The following is a description of a gene set: Human Gene Set: BAE_BRCA1_TARGETS_DN Genes concordantly down-regulated in DU-145 and MCF-7 cells (lprostate, breast cancer) upon expression of BRCA1. from publication Bae I, Fan S, Meng Q, Rih JK, Kim HJ, Kang HJ, Xu J, Goldberg ID, Jaiswal AK, Rosen EM (PMID 15520196) species: Homo sapiens Mutations of the breast cancer susceptibility gene 1 (BRCA1), a tumor suppressor, confer an increased risk for breast, ovarian, and prostate cancers. To investigate the function of the BRCA1 gene, we performed DNA microarray and confirmatory reverse transcription-PCR analyses to identify BRCA1-regulated gene expression changes. We found that BRCA1 up-regulates the expression of multiple genes involved in the cytoprotective antioxidant response, including glutathione S-transferases, oxidoreductases, and other antioxidant genes. Consistent with these findings, BRCA1 overexpression conferred resistance while BRCA1 deficiency conferred sensitivity to several different oxidizing agents (hydrogen peroxide and paraquat). In addition, in the setting of oxidative stress (due to hydrogen peroxide), BRCA1 shifted the cellular redox balance to a higher ratio of reduced to oxidized glutathione. Finally, BRCA1 stimulated antioxidant response element-driven transcriptional activity and enhanced the activity of the antioxidant response transcription factor nuclear factor erythroid-derived 2 like 2. The ability of BRCA1 to stimulate antioxidant response element-dependent transcription and to protect cells against oxidative stress was attenuated by inhibition of nuclear factor erythroid-derived 2 like 2. These findings suggest a novel function for BRCA1, i.e., to protect cells against oxidative stress. This function would be consistent with the postulated role of BRCA1 as a caretaker gene in preserving genomic integrity., and this is the list of marker genes: CAD, TNFAIP6, ZNF135, HIPK3, EBI3, CRAT, THBS1, TCOF1, STIL, TJP1, NPM1, TJP2, BAG1, GLUD1, TNFAIP3, IREB2, HYOU1, MYB, MAN1A2, ADD2, CYP27A1, LAMC1, JAK1, MT1F, AQP4, PEX2, PKN2, NONO, TKT, SMAD5